The following is a description of a gene set: electronically inferred by orthology from the curated human pathway part of: Caspase activation via extrinsic apoptotic signalling pathway Reactome Pathway: Caspase activation via Dependence Receptors in the absence of ligand This event has been computationally inferred from an event that has been demonstrated in another species.<p>The inference is based on the homology mapping from PANTHER. Briefly, reactions for which all involved PhysicalEntities (in input, output and catalyst) have a mapped orthologue/paralogue (for complexes at least 75% of components must have a mapping) are inferred to the other species. species: Mus musculus, and this is the list of marker genes: Casp9, Casp3